The following is a description of a gene set: Genes containing one or more binding sites for (RUVBL1) in their promoter regions (TSS -1000,+100 bp) as identified by GTRD version 20.06 ChIP-seq harmonization. Human Gene Set: RUVBL1_TARGET_GENES from publication Yevshin I, Sharipov R, Kolmykov S, Kondrakhin Y, Kolpakov F (PMID 30445619) species: Homo sapiens, and this is the list of marker genes: EEF1A1, C11orf54, EIF1AD, TMEM18, ZBTB4, SRGAP3, SDCBP2-AS1, VTRNA1-1, C1orf174, RCC1, ARHGDIA, POLR2A, PUM1, ITFG2-AS1, FTSJ3, SENP1, VTRNA1-3, ARL6IP1, DMAC2, CEP95, MIR3193, THUMPD3, NKAPD1, TANK (NCBI Gene Id 10010), SRCAP, LINC02136, BCAR3, USP1, CFAP418, C2orf42, ATP7B, PPEF1, ACYP2, RNU1-1, TRIM7-AS2, LDLR, TAF1D, PHB2, ANKRD17-DT, ENPP3, MITD1, RNVU1-6, MMADHC, SNORA24, RNASE11, BICRAL, C17orf75, NACA, ATF2 (NCBI Gene Id 1386), THAP2, ENSG00000246308, RAB11A, FN1-DT, CCDC47, FMC1, LINC01719, MZT2B, PRORP, H4C8, DPP9, LINC01962, SMPD4, RNASE4, AAR2, PLXDC1, RN7SK, PSMC5, TRIP4, RPS12, POLG, CENPK, ZKSCAN2, PFKM, FBXO31, H2BC4, PIH1D2, MRPL30, SRSF3, SNHG8, DDX5, ZNFX1, TANK-AS1, PRMT5-DT, SNRPB, ZNF839, ITFG2, ATP5MC2, SLX4IP, MIR933, B4GAT1-DT, B4GAT1, BANF1, ANG, SEC23B, TBCC, PRMT5, SNORD12B, SERBP1, HSP90AB1, RBM48, H2AC6, SPATA2, TIA1, MYNN, RNU11, RPL26, KRBOX5, MKKS, SNHG3, RNU5A-1, UBAC2, ILF2, PBLD, HJV, GSTA4, GPT2, PEX1, ALOXE3, TTI1, UBAC2-AS1, MAP1LC3B, PPP2R3C, RPL7L1, TMEM242, ALG11 (NCBI Gene Id 440138), FMC1-LUC7L2, RNU5B-1, PCBP1-AS1, RABGGTB, NDUFS7, ZNF653, HNRNPC, IPO4, PPP6R3, METTL1, RPL11, RPL18, CCNG2, DDX42, LIMD1-AS1, TPD52L2, RPL41, RPRD1B, TET2, ZFC3H1, EEF1AKMT3, LRP3, RPS14, LINC01623, EIF4G2, EMG1, PRDX1, HSPA6, PPWD1, TMEM242-DT, CHD2, POLR3E, SPHK2, PCLAF, NCOA7, MYLK-AS1, BCLAF1, PRKRA, SHF, HCG14, ZNF408 (zinc finger protein 408), SNORD45C, MED23, LTA4H, POLG-DT, VTRNA1-2, IMPDH2 (NCBI Gene Id 3615), ANKRD17, ZNF207, SACM1L, EPCAM-DT, UFC1, SNRPG, RPL24, HACD2, ARHGAP1